Given this list of marker genes Zw10, Cdc20, Bub1, Cenpl, Mad2l1, Xpo1, Tubb2b, Seh1l, Dync1li2, Spdl1, Diaph1, Tubb4b, Nup98, Diaph3, Ska1, Nup37, Scai, Cenpp (NCBI Gene Id 70914), Mapre1, Actb, Ppp2ca, Ppp2r1b, Rhob, Pafah1b1, Tuba1c, Ckap5 (NCBI Gene Id 97044), Src, Cenpa, Nup85, Rcc2, Fmnl3, Pfn1, Ppp2r5c, Rhoc, Tubal3 (NCBI Gene Id 238463), Ppp2r1a, Cdca8, Kntc1, Cenph, Ppp1cc (NCBI Gene Id 627816), Cenpi, Zwint, Dync1i2, Clip1, Pfn2, Ppp2r5e, Fmnl1, Dvl1, Rps27rt, Plk1, Cenpc1, Tuba3b, Sgo2a, Tubb3, Tubb2a, Rhod, Cenpn, Rps27, Spc25, Ppp2cb, Cenpf, Ppp2r5d, Fmnl2, Rhoa, Tuba1a, Tuba1b, Cdc42, Ska2, Tubb1, Dsn1, Evl, Ranbp2, Cenpu, Rangap1, Tuba8, Zwilch, Bub1b, Nsl1, Ndel1, Dynll2, Dvl3, Cenpe, Cenpm, Cenps, Mad1l1, Kif2b, Clasp1, Daam1, Ppp2r5a, Cenpt, Cenpq, Nup43, Taok1 (NCBI Gene Id 67240), Pmf1, Kif2c, Nudc, Itgb3bp, Dynll1, Dync1i1, Srf, Aurkb, Incenp (NCBI Gene Id 98139), Cenpk, Nuf2, B9d2, Dvl2, Tubb6, Tuba3a, Actg1, Tuba4a, Nup133, Clasp2, Dync1li1, Srgap2, Ercc6l, Diaph2, Spc24, Tubb4a, Mis12, Nde1, Kif18a, Dync1h1, Ppp2r5b, Sgo1, Kif2a (kinesin family member 2A), Mrtfa, Nup160, Rac1, Bub3, Nup107, Ndc80, Ahctf1, Sec13, Cenpo, here is a description of the gene set: RHO GTPases Activate Formins studied in species Mus musculus Mouse Gene Set: REACTOME_RHO_GTPASES_ACTIVATE_FORMINS